The following is a description of a gene set: Mouse Gene Set: GOBP_NEGATIVE_REGULATION_OF_CHEMOKINE_PRODUCTION Any process that stops, prevents, or reduces the frequency, rate, or extent of chemokine production. species: Mus musculus, and this is the list of marker genes: Cd24a, Oas1g, Sigirr (single immunoglobulin and toll-interleukin 1 receptor (TIR) domain), Lilrb4b, Mefv, Apod, Gstp2, Klf4, Nr1h4, Ticam2, Oas1d, Oas3, Oas1f, Mul1, Erbin, Lilrb4a, Suz12, Elane, Arg2, Oas1e, Gstp3, C1qtnf3, Epha2, Gstp1, Sirpa, Il6, Map2k5, Socs5, Slc37a4, Gstp-ps, Oas1c, Oas1a, Oas1h, F2rl1, Oas1b